Given this list of marker genes Rfc1, Acd, Terf2, Terf1, Chtf18, Prim1, Rfc3, Pola2, Pold4, Pcna, Pold1, Pola1, Chtf8, Pold2 (polymerase (DNA directed), delta 2, regulatory subunit), Ctc1, Ten1, Dscc1, here is a description of the gene set: This event has been computationally inferred from an event that has been demonstrated in another species.<p>The inference is based on the homology mapping from PANTHER. Briefly, reactions for which all involved PhysicalEntities (in input, output and catalyst) have a mapped orthologue/paralogue (for complexes at least 75% of components must have a mapping) are inferred to the other species. Reactome Pathway: Polymerase switching on the C-strand of the telomere species: Mus musculus electronically inferred by orthology from the curated human pathway part of: Telomere C-strand (Lagging Strand) Synthesis